Given this list of marker genes ATP6V1D (NCBI Gene Id 51382), UCP2, ATP5F1D, ATP5F1C, ATP6V1F, UCP1, ATP6V0B, ATP5PO, ATP6V1G1, ATP6V0C, ATP5MC2, ATP5MC3, ATP5F1B, ATP6AP1, ATP5MC1, ATP5PD, ATP6V1B2, ATP5ME (ATP synthase membrane subunit e), ATP5F1E (ATP synthase F1 subunit epsilon), ATP6V1E1, ATP6V0E1, CSPG4, ATP5PF, ATP6V1H (NCBI Gene Id 51606), ATP5MF, ATP6V0D1, ATP5MG, ATP6V0A1, ATP5F1A, here is a description of the gene set: Human Gene Set: MODULE_116 studied in species Homo sapiens Genes in the cancer module 116.